The following is a description of a gene set: A process in which a protein is transported to, or maintained in, a location within the nucleoplasm. Mouse Gene Set: GOBP_PROTEIN_LOCALIZATION_TO_NUCLEOPLASM studied in species Mus musculus, and this is the list of marker genes: Wrap53, Tbrg1, Nop53, Larp7, Mepce, Larp7-ps